The following is a description of a gene set: A kind of polydactyly characterized by the presence of a supernumerary finger or fingers. Hand polydactyly species: Homo sapiens Human Gene Set: HP_HAND_POLYDACTYLY, and this is the list of marker genes: LZTFL1, ARVCF, RREB1, CEP290, DEAF1, HEATR3, EVC2, EBP, PRKACB, MKKS, TMEM67, GDF5, ALX3, SHH, CD96, TMEM216, IFT80, MEGF8, CSPP1, SUFU, TCTN1, KATNIP, PORCN, GPC3, RPGRIP1L, IQCE, JMJD1C, SH2B1, GLI2, ZNF699, BBS12, FANCB, KIAA0825, DHCR7, CDC45, OTUD5, FLII, NEK1, TMEM138, RAB23, CPLANE1 (ciliogenesis and planar polarity effector complex subunit 1), TFAP2B (NCBI Gene Id 7021), WNT7A, CBY1 (chibby 1, beta catenin antagonist), PDE6D, LHX4, DYNC2I2, HEPACAM, PIK3R2, PRKACA, IQSEC2, GLI1, TBX3, TMEM107 (NCBI Gene Id 84314), PHF8, HOXD13, SMO, SEC24C, IFT27, PIK3CA, LHX3, MAFB, PIGG, FAM149B1, COMT, ARMC9, NSD2 (nuclear receptor binding SET domain protein 2, NCBI Gene Id 7468), DYNC2H1, KIAA0586, IFT140, SALL4 (NCBI Gene Id 57167), KIF7, UFD1, FLI1, CHD7, WDR35 (NCBI Gene Id 57539), ZSWIM6, SALL1, SMOC1, TMEM231, HOXA13, IFT172, DYNC2I1, DPYSL5, TBX5, EFNB1, LMBR1, BBS2, CEP104, BMPR1B, ARL3, B9D1, SCNM1 (NCBI Gene Id 79005), HYLS1, RAB34, MKS1, CEP41, SC5D, FGFR2, CFAP418, POU1F1, INPP5E, TTC21B, PIBF1, MBTPS2, FANCD2, HESX1, RBM10, C2CD3, B9D2, LBR, TOGARAM1, MAX, CPLX1, TMCO1, LETM1, DDX59, EFTUD2, TOPORS, GJA1, TFAP2A, AHI1 (Abelson helper integration site 1), TWIST1, DACT1, PTEN, BBS1, WASHC5, TGFBR1, NPHP1, FGFRL1, VPS35L, TMEM218, IFT74, CCDC28B, FLNA, CHSY1, CEP120, ARL6, TBX1, KIAA0753, GLI3, ACOX1, CC2D2A, CIBAR1, RPGRIP1, BBS9, CCDC22, PROP1, AKT3 (NCBI Gene Id 26068), WDPCP, ZIC3, ZNF141, CCND2 (cyclin D2), BHLHA9, TCTN2, HIRA, MAP3K20, GPC4, EVC, SETBP1, CHN1, TMEM237, OFD1, ARL13B, CTBP1, DYNC2LI1, GP1BB, WDR19, TCTN3, ABCA12, PUF60 (poly(U) binding splicing factor 60), PLAA, DYNLT2B, EXTL3, TXNDC15, RAI1, ZNF423, PNPLA6, NELFA, BLM